The following is a description of a gene set: Reactome Pathway: Molybdenum cofactor biosynthesis This event has been computationally inferred from an event that has been demonstrated in another species.<p>The inference is based on the homology mapping from PANTHER. Briefly, reactions for which all involved PhysicalEntities (in input, output and catalyst) have a mapped orthologue/paralogue (for complexes at least 75% of components must have a mapping) are inferred to the other species. electronically inferred by orthology from the curated human pathway part of: Metabolism of water-soluble vitamins and cofactors species: Mus musculus, and this is the list of marker genes: Mocos, Mocs3